Given this list of marker genes C1QTNF12, ZFP28, TAL1 (TAL bHLH transcription factor 1, erythroid differentiation factor), UNC5A, ENOX1, LPIN1, CFAP107, PCBP1, ALAS1, PTDSS2, SNX15, ERC2, NUP42, NDUFA11, ABCB4, KIF22, ACSL6, RAB3B, S100A3, RASAL1, UCN, RAD51AP1, ILDR1, RRP15, PEX2, SNN, CLCN2, PKMYT1, ATP7B, PCCB, E2F8, GJA1, LSM7, OPTN, GALE, KCTD7, TRIM67, GATA1, ACSL1, DDX59, PODXL, SGO1, TNNT2, SUPV3L1 (NCBI Gene Id 6832), MRPS31 (NCBI Gene Id 112759), SCUBE3, CUEDC2 (NCBI Gene Id 79004), PRXL2A, WDR12, TNNI3, DENND4A, SECISBP2 (NCBI Gene Id 79048), TTC27, CFAP251, MYB, ALDH2, TSC22D1, TRAIP, SSC4D, TRPM1, SPC24, PRDM4, TSNAXIP1 (translin associated factor X interacting protein 1), CPSF4L, MAPK8IP3, TMEM177, TNK1, POLR2F, MRPL2, NNT, KRT85, SRM, MFSD2B, DENND2B, SNAI3-AS1, ZNF408, IFRD2, MATCAP2, IRF4, PGAP4, GATB, SYCE2, KLF1, GLS2, TNFAIP2, FIRRE, RCBTB2, MRPL3, MYLK3, NSMCE4A, LMAN1, GATM, PTPRJ, POMC, LRRC36, ASB6, CAGE1, FAHD2A, OGFRL1, LONP1, WDFY1, TFR2, TMPRSS11D, AREL1, SMCR8, GRAMD1A, CCDC110, IDH2, YDJC, WDHD1, PLA2G10, POLDIP2, SLC39A7, NTN4, PSMG3, STARD10, LIFR, CDC6, EXO5, NAA80, DARS2, NSMCE3, VPS33B, NAPB, CKS1B, SASS6 (SAS-6 centriolar assembly protein), POLG2, SGSM3, TMOD1, TEX22, HARS2, ZNF410 (zinc finger protein 410), CCDC172, YJU2, AQP1, EPHX2, GFI1B, DAPK2, LACTB2, PLEK2, GIPC1, PIGQ, H3C4, CSNK2A2, ANGPTL4, TINAGL1, STX2, EGFL7, MAP2K4, GTF3C5, LDHC, FABP4, MLH1, C7orf50, GDA, NUDT12, YEATS2, MCM10, KCTD14, SVIP, COA8, GPAA1, MTFR2, KIF2C (NCBI Gene Id 11004), XRCC3, PYROXD1, ITSN1, HEXA, COL5A1, TLE5, ANK1, MMP14, CPNE2, SAC3D1, CCT6A, ZNF335, CEP70, CKB, TTLL4, MLLT3, UMPS, ZMAT5, SFXN2, PGK2 (phosphoglycerate kinase 2), SLC22A23, SPHK1, FGF6, CPVL, ARAP3, MT2A, APCS (amyloid P component, serum), PRX, CENPK, RANBP1 (NCBI Gene Id 5902), PRSS56, NOS3, GADD45GIP1, ATP1B2, DIS3L, STOM, here is a description of the gene set: Genes up-regulated in bone marrow-derived macrophages with PPARG knockout: control versus IL4. Human Gene Set: GSE25123_CTRL_VS_IL4_STIM_PPARG_KO_MACROPHAGE_UP studied in species Homo sapiens from publication Szanto A, Balint BL, Nagy ZS, Barta E, Dezso B, Pap A, Szeles L, Poliska S, Oros M, Evans RM, Barak Y, Schwabe J, Nagy L (PMID 21093321) Conditional macrophage-specific PPARg knockout mice were generated on C57Bl/6 background by breeding PPARg fl/- (one allele is floxed, the other is null) and lysozyme Cre transgenic mice. PPARg and IL-4 signaling was analyzed on bone marrow-derived macrophages. Bone marrow of 3 mice per group was isolated and differentiated to macrophages with M-CSF (20 ng/ml). 20 ng/ml IL-4 was used to induce alternative macrophage activation and 1 uM Rosiglitazone (RSG) was used to activate PPARg. From each mouse 4 samples were generated: 1. M-CSF, 2. M-CSF+RSG, 3. IL-4 and 4. IL-4+RSG. All compounds were added throughout the whole differentiation process, and fresh media was added every other day. Control cells were treated with vehicle (DMSO:ethanol). After 10 days, RNA was isolated and gene expression profiles were analyzed using Mouse Genome 430 2.0 microarrays from Affymetrix.